The following is a description of a gene set: from publication Gavish A, Tyler M, Greenwald AC, Hoefflin R, Simkin D, Tschernichovsky R, Galili Darnell N, Somech E, Barbolin C, Antman T, Kovarsky D, Barrett T, Gonzalez Castro LN, Halder D, Chanoch-Myers R, Laffy J, Mints M, Wider A, Tal R, Spitzer A, Hara T, Raitses-Gurevich M, Stossel C, Golan T, Tirosh A, Suvà ML, Puram SV, Tirosh I (PMID 37258682) Human Gene Set: GAVISH_3CA_MALIGNANT_METAPROGRAM_37_HEMATO_RELATED_2 species: Homo sapiens Genes upregulated in subsets of cells of a given type within various tumors In this study, an extensive analysis was conducted to define meta-programs (MPs) capturing intra-tumor heterogeneity across a spectrum of tumor types. The approach utilized non-negative matrix factorization (NMF) to analyze each cell type separately within individual tumor samples. This involved the analysis of malignant cells, macrophages, fibroblasts, endothelial cells, epithelial cells, T-cells, and B-cells. NMF was executed with varying parameter values (K=4, 5, 6, 7, 8, 9), thereby generating 39 programs for each cell type per sample. Each NMF program was summarized by the top genes based on NMF coefficients.\nRobust MPs were then delineated for each cell type using a set of stringent criteria, including recurrence within the same tumor, similarity to programs in other tumors, and non-redundancy within a tumor. Subsequently, these robust NMF programs were clustered (per cell type) based on Jaccard similarity, leading to the identification of MPs associated with each cell type.\nTo enhance the quality of the MPs, a refinement steps were undertaken, involving the removal of MPs suspected of reflecting low-quality data (with an overrepresentation of ribosomal proteins or mitochondrial-encoded genes), single-study inclusion, or similarity to miss-annotated cell types., and this is the list of marker genes: TPSB2, NFE2, TAFA2, CPPED1, DEPTOR, SOD2, FCER1A, GMPR, HPGDS, IL1B, SOX4, KCNQ1OT1, MINPP1, CTNNBL1 (catenin beta like 1), FAM117A, KLF1, TESPA1, ICAM4, GATA2, ATP6V0A2, CNRIP1, PLIN2, RGS18, PBX1, PDLIM1, CYTOR (NCBI Gene Id 112597), PKIG, CYTL1, CASP3, ZEB2, FREM1, CD82, EREG, RAB37, ALDH1A1, PDZD8, ZMYND8, STAM, PDCD4, SLC40A1, PLEK, ABCC4 (NCBI Gene Id 10257), BMP2K, LXN, CD84, STXBP6, CPA3, HBD, MPP1